Given this list of marker genes CREB1, MAPKAPK2, RPS6KA5 (ribosomal protein S6 kinase A5), ATF1, RPS6KA1, RPS6KA2, RPS6KA3, here is a description of the gene set: CREB phosphorylation Human Gene Set: REACTOME_CREB_PHOSPHORYLATION species: Homo sapiens